Given this list of marker genes Itgam (integrin alpha M), Snca, Comt, Htr2c (NCBI Gene Id 15560), Atp7a, here is a description of the gene set: Any process that stops, prevents, or reduces the frequency, rate or extent of the chemical reactions and pathways involving catecholamine. Mouse Gene Set: GOBP_NEGATIVE_REGULATION_OF_CATECHOLAMINE_METABOLIC_PROCESS species: Mus musculus